The following is a description of a gene set: Human Gene Set: GOBP_RNA_POLYMERASE_II_TRANSCRIPTION_INITIATION_SURVEILLANCE species: Homo sapiens A process that promotes premature RNA polymerase II transcription termination of transcripts that are unfavorably configured for transcriptional elongation by releasing RNA polymerase II from bound DNA or promoting RNA polymerase II degradation., and this is the list of marker genes: INTS13, INTS14, PPP2R1A, INTS8 (integrator complex subunit 8), INTS9, INTS6, INTS10 (integrator complex subunit 10), INTS7, PPP2CA, INTS4, RBX1, INTS5, ARMC5, INTS15, INTS12, INTS1, INTS11, INTS3, INTS2